The following is a description of a gene set: Any process that stops, prevents or reduces the frequency, rate or extent of non-canonical NF-kappaB signaling cascade. studied in species Mus musculus Mouse Gene Set: GOBP_NEGATIVE_REGULATION_OF_NON_CANONICAL_NF_KAPPAB_SIGNAL_TRANSDUCTION, and this is the list of marker genes: Mkrn2, Cyld, Uaca, Spi1, Ifi35, Adipor1, Ddx3x, Nlrc3, Nmi, Zc3h12a, Nlrp3, Fbxw11, Trim60, Hdac7, Capn1, Nlrp12, Ppm1a, Litaf, Rela, C1qtnf3, Ndufc2, Trim15, Ppm1b, Rassf2 (NCBI Gene Id 99374), Adgrg3, D1Pas1 (DNA segment, Chr 1, Pasteur Institute 1), Cpne1, Ccn3